The following is a description of a gene set: species: Homo sapiens Human Gene Set: GOBP_NEGATIVE_REGULATION_OF_ENDOTHELIAL_CELL_CHEMOTAXIS Any process that stops, prevents or reduces the frequency, rate or extent of endothelial cell chemotaxis., and this is the list of marker genes: MIR149, HRG, MIR16-1, CXCL13, THBS1, MIR424, NOTCH1